Given this list of marker genes Slc30a4 (solute carrier family 30 (zinc transporter), member 4), Slc30a2, Slc30a10, Slc30a1, Tmem163, Slc30a5, Slc30a6, Ap3d1, Slc30a3 (NCBI Gene Id 22784), Slc30a7, Slc30a8, here is a description of the gene set: The directed import of zinc(2+) from the cytosol, across an organelle membrane, into the organelle. Mouse Gene Set: GOBP_ZINC_ION_IMPORT_INTO_ORGANELLE species: Mus musculus